The following is a description of a gene set: studied in species Mus musculus A process that chemically modifies 5-methylcytosine (5meC) to make it a substrate for the base excision repair pathway, which then restores the unmodified cytosine. Mouse Gene Set: GOBP_CHROMOSOMAL_5_METHYLCYTOSINE_DNA_DEMETHYLATION_PATHWAY, and this is the list of marker genes: Tet2, Tet3, Tet1, Hnrnpab, A1cf, Syncrip, Apobec1